The following is a description of a gene set: species: Homo sapiens mouse primary BMDCs were stimulated with tlr ligands and gene expression changes were profiled on Affymetrix arrays Genes down-regulated in comparison of control dendritic cells (DC) at 4 h versus those stimulated with poly(I:C) (TLR3 agonist) at 4 h. Human Gene Set: GSE17721_CTRL_VS_POLYIC_4H_BMDC_DN from publication Amit I, Garber M, Chevrier N, Leite AP, Donner Y, Eisenhaure T, Guttman M, Grenier JK, Li W, Zuk O, Schubert LA, Birditt B, Shay T, Goren A, Zhang X, Smith Z, Deering R, McDonald RC, Cabili M, Bernstein BE, Rinn JL, Meissner A, Root DE, Hacohen N, Regev A (PMID 19729616), and this is the list of marker genes: RBM43, KLRK1, ROR2, UPP1, NPY1R, CBLN1, CLEC5A, PARP4, KDR, IRF8, ZNF689, IRGM, EBNA1BP2, WASHC4, GSAP, ZIM3, MID1, HTR5A, HELZ2, VSTM2B, IL1RN, TAB2, CD38, CHD1, FNBP4, NEURL1, MITF, HCN2, TDRD7, SLC30A3, CLCN1, NR2F1, C19orf12 (NCBI Gene Id 83636), MRPL21, MOB1B, SFXN4, CXCL9, BEST2, ABR, ADHFE1, PROCR, GCH1, ADAP2, CMTM6, HCAR2, MAP3K12, IL18BP, MITD1, ZNF354C, CD27, NUPR1, TNFSF9, CNMD, CLDND1, ZC3H12C, ASB3, RSAD2, SERPINB2, FBXW11, HTRA2, FLG, TSC22D1, DUSP2, PTGS2, PCNX1, STX1A, NEU3, SAMD10, MTMR14, ZNFX1, CDH3, ADGRG1, VCAN, TBK1, TXNIP, WDR86, C11orf68, ETNK1, EYA1, STARD3, LRRC41, PLEKHN1, PPP2R5A, NR3C1, CHST15, CAV1, PPP1R15A, COL4A2, SLC26A1, KPTN, STAB2, CCL2, EHD1, RAB8B, PSMB9, IFNAR1, TMEM106A, PDE4B, FABP3, GBP2, TRIM34, BLOC1S6, ATP10A, MYH1, N4BP1, STARD5, CWC15, KCND2, DOP1B, ETS2, MS4A6A, PARP3, PEX13 (peroxisomal biogenesis factor 13), OSTF1, CARHSP1, BHLHA15, ZNRF1, ARL14EP, NUB1, SCHIP1, AGTRAP, DHX58, ZNF296, SPRYD7, DTX2, MYO1D, TMEM266, CDKN1A, NHERF4 (NCBI Gene Id 79849), NIF3L1, CCNL1, GTPBP2, G3BP2, EPSTI1, SLC17A1, TTC39C, CEBPD, GLCCI1, DENND2D, CASP4, PIK3AP1, CRLF3, PEX26, SIK1, NUDT9, CBS, SLAMF8, SLC39A1, FLNB, VCL, EXOC6, UNK, SHROOM1, LCN8, FGF4, PALLD, ABCC8, ENDOD1, SOS1, NAMPT, YTHDC1, MSL2, CAPZA2 (NCBI Gene Id 830), XRN1, CCDC71L (NCBI Gene Id 168455), FMOD, ELL2, H2AC25, SMC5, PSMA4 (proteasome 20S subunit alpha 4), IKBIP, MEP1B, USP25, NPR1 (natriuretic peptide receptor 1), CD82, MAPKAPK2, CSF3R, DAB2, FBLN5 (NCBI Gene Id 11268), PAG1, HNRNPUL1, HOOK2, DGAT2, SLC38A5, KCMF1, EMID1, IL18RAP, SFTPA1, GNAT2, STAU1, FUNDC2, ATF3, SERTAD1, SUZ12, SHMT1, TAP1, PARP12, PDK3, SSTR1, PLPP1